Given this list of marker genes Uba6, Sf3a3, Ino80b, Psmc5, Lonp1, Mettl23, Tmem101, Pex12, Lrrc41, Btrc, Nedd8, Uqcrh, Tnks1bp1, Jmjd6, Sart1, Cenpu, Arhgef1, Zfp113, Gm15764, Ap2b1, Pla2g6, Snrpd3, 2810013P06Rik, Gucd1, Gmpr2, Ftsj3, here is a description of the gene set: Mouse Gene Set: RHOX11_TARGET_GENES species: Mus musculus Genes containing one or more binding sites for (Rhox11) in their promoter regions (TSS -1000,+100 bp) as identified by GTRD version 20.06 ChIP-seq harmonization. from publication Yevshin I, Sharipov R, Kolmykov S, Kondrakhin Y, Kolpakov F (PMID 30445619)